Given this list of marker genes Mef2c, Plxna4, Ece1, Ednra, Edn1, here is a description of the gene set: Mouse Gene Set: GOBP_SYMPATHETIC_NEURON_AXON_GUIDANCE studied in species Mus musculus The chemotaxis process that directs the migration of a sympathetic neuron axon growth cone to a specific target site in response to a combination of attractive and repulsive cues.